The following is a description of a gene set: Mouse Gene Set: TABULA_MURIS_SENIS_MESENTERIC_ADIPOSE_TISSUE_CD8_POSITIVE_ALPHA_BETA_T_CELL_AGEING studied in species Mus musculus from publication Tabula Muris Consortium (PMID 32669714), and this is the list of marker genes: Dcn, H2-Aa, Jund, Tle5, Tmsb10, Ccdc80, Ccl5, Arhgdia, Kdm6b, Cst3, Sod1, Evl, Gpr132, Rpl13a, Rps3, Apoe, Klf13, Cfl1, Bsg